Given this list of marker genes SPP1, IGHG1, ITGAM, JAZF1, MECP2, BANK1 (B cell scaffold protein with ankyrin repeats 1), PTPN22, TNIP1, IRF5 (interferon regulatory factor 5), UBE2L3, C4A, FCGR3B, CR2, KIAA0319L, BLK, IRAK1, PDCD1, STAT4, C4B, TNFSF4, CTLA4, SAT1, FCGR2B, TREX1, PLCG1, ETS1, SERPING1 (serpin family G member 1), PRKCD, DNASE1, TNFAIP3, PXK, TLR7, DNASE1L3, IL10, HLA-DRB1, here is a description of the gene set: studied in species Homo sapiens Human Gene Set: HP_DECREASED_CIRCULATING_COMPLEMENT_C4_CONCENTRATION Concentration of the complement component C4 in the blood circulation below the lower limit of normal. Decreased circulating complement C4 concentration